The following is a description of a gene set: species: Homo sapiens from publication Chen Y, Wang X (PMID 31504780) Human Gene Set: MIR6774_3P Genes predicted to be targets of miRBase v22 microRNA hsa-miR-6774-3p in miRDB v6.0 with MirTarget v4 prediction scores > 80 (high confidence targets)., and this is the list of marker genes: STAU2, RASD1, ENSG00000215022, TRPC7, VGLL3, SLC6A19